Given this list of marker genes Pgap1, Tbc1d20, Use1, Stx18, Arf1, Scfd1, Rnf139, Yipf5, Gas1, Sorl1, Rint1, Lrrk2, here is a description of the gene set: Mouse Gene Set: GOBP_REGULATION_OF_ER_TO_GOLGI_VESICLE_MEDIATED_TRANSPORT studied in species Mus musculus Any process that modulates the rate, frequency, or extent of ER to Golgi vesicle-mediated transport, the directed movement of substances from the endoplasmic reticulum (ER) to the Golgi, mediated by COP II vesicles. Small COP II coated vesicles form from the ER and then fuse directly with the cis-Golgi. Larger structures are transported along microtubules to the cis-Golgi.